Given this list of marker genes ABL1, MTSS1, FAHD1, METTL9, HOXA1, MTMR10, MCRIP2, RER1, SERPINB10, PPP3R1, PHF7, PAQR7, RABGGTB, ZC3H8, UROS, FUBP1, PAN3, BRD3, NSD1, UBE2G1, FMNL3, RABEP1, UNC119B, ADAMTSL3, TERF2, TREM2, NARF, CCDC88B, MVD, ZFPM1, AGA, USP53, DNMBP, NAA40, NOP2, MTF2, SCAI, ACAP1, CNNM3, SNAPC4, UBR2, PABPN1, PRKAG2, CLSPN, KAT6B, PLA2G5, HNRNPD, EFCAB7, RRP8, FAM118B, POLR3E, SESN1, TBC1D16, KIF21B, HEXIM1, CCDC47 (coiled-coil domain containing 47), ERBB3, ABLIM2, CD9, HDAC4, PAIP1, MT-CO1, ATP6V0E1, RNF169, B3GALT6 (beta-1,3-galactosyltransferase 6), TRMT5, KLHL6, GDF3, KICS2, GIMAP6, MON2, SNRNP70, RGL2, PLEKHJ1, ATP13A3, RDH13, LRP6, ZMYND19, NXT1, EIF2AK4, MPV17L, FLCN, FAM199X, TANGO6, RPRD1A, TXNDC17, TMEM42, SEZ6L2, NELFCD, THAP2, TRIM27, EIF1B, MAP4K5, ADGRG3, IMPACT, EMC6, PDS5A, B4GALT7, CNOT2, NR2F6, GNE, CCL3, RMDN1 (NCBI Gene Id 51115), RALGAPB, LSM14B, ANXA5, TMEM185B, CD5, MEGF10, LHFPL2, RBM38, COLEC12, GTSF1, IPO7, TBC1D8, IQCE, GTF2E2, DGKG, PRDM15, ADO, FEM1A, RNMT, PPP1R3F, FBXL20, SRFBP1, DGKD, SAMD8, SLC25A36, SSNA1, PTP4A1, TSPOAP1, HEATR6, PHF3, PPAN, SSX2IP, NBEAL1, SLC25A40, PDE4DIP, PANK1, ZC3H12C, EPHA2, RRAD, SHPRH, FNIP1, CLEC4E (C-type lectin domain family 4 member E), SPRED2, CDC42, FIP1L1, PHF2, FHOD1, C2CD2, IGSF6 (NCBI Gene Id 10261), AGO1, NLE1, DAPK1, GGH, FYTTD1, here is a description of the gene set: Genes down-regulated during B lymphocyte differentiation: pre-B I versus VPREB1+ large pre-B II. species: Homo sapiens Human Gene Set: GSE4590_PRE_BCELL_VS_VPREB_POS_LARGE_PRE_BCELL_DN from publication Hoffmann R, Lottaz C, Kühne T, Rolink A, Melchers F (PMID 17890238) Cells from four develppmental stages were purified by FACS from human bone marrow samples